The following is a description of a gene set: Genes having at least one occurrence of the motif NGRCWTGYCY in the regions spanning 4 kb centered on their transcription starting sites. This matches the TP53 transcription factor binding site V$P53_02 (v7.4 TRANSFAC). studied in species Homo sapiens Human Gene Set: P53_02, and this is the list of marker genes: SYT4, GNG3, CA9, NRG1, LIPT2-AS1, PPP1R12A, GPD2, SEMA7A, DDR1, S100PBP, KDM4C, CITED4, CRAT, MYH11, HCAR2, DTNA, DNALI1, GCNT2, MDM2, HIP1R, SRSF5 (NCBI Gene Id 6430), BCAM, HOXB1, MDK, RAB1B, TJP2, RAP1B, DSCAML1, VCPKMT (valosin containing protein lysine methyltransferase), REPIN1, ESRRG, DNAH6, MYOT, CIDEC, PTH1R, CALD1, TRIM29, LINC01565, MIP, SLC12A6, RTL3, SBF2, MEMO1, ELF4, PLA2G4E (phospholipase A2 group IVE), LZTR1, ACSL5, PSME2, HS6ST3, SLITRK1, MBNL1, SLITRK4, CTNND2, NUP93, MBNL2, MRC2, BCL11A (NCBI Gene Id 55085), SUMO4, NAPG, TMEFF1, FBRS, BRAF, ASIC4, KRT15, CXXC4, PITPNC1, HIC1, KDM2A, CPNE1, PKP3, NACC1, NIPBL, MMP28, CARMIL3, ZNF654, PTPN22, ARRDC4, SH3BP1, EPB41L1, NTRK3, SRSF6 (NCBI Gene Id 6431), H3-3A, EI24, ELK3, PRKAG1, FLRT1, MAF, SLC25A17, ARHGAP44, ASIC2, MITF, TMC7, DYRK1B, WBP1L, VAV3, HNRNPA0, COPB1, LMTK2, GABRR2, ERO1B, LPP, NXPH1, KIF16B, SYT13, MLEC, DSEL, SRRM4, PML, MARCHF1, PRDX5, FILIP1, GADD45B, RHOBTB2, PLCB3 (NCBI Gene Id 5331), SOX5, HOXA11, BCL11B, TRERF1, NDP, TFAM, CTRL, MBD6, OTX1, PRDM8, RORC, PTPA, PAK5, ENPP2, OPA3, CHUK, MAGEL2, ATP6AP1, CNR1, RPS27L, ANKRD53, MAP4, INHBB, ABCA12, RNF144B, TFDP2, FAM83H, SCN2A, SOX4, HMGN3, TSC22D1, MECR, DCAF7, PITX3, CHRM1, MTA2, LRRK1, ANXA1, STARD8, POLR1G, SLC1A3, ADAMTS4, PREX2, NUDCD1, OTX2, CACNB2, NR4A3, KBTBD8, RNF17, DENND2B, MEIS2, PPL, DNAJB5, TRMT112, PTPRG, AKAP6, AIM2, PIK3R2, PLCB1, DGKZ, MYL3, C6orf62, GATA4, DDIT3, FHDC1, MAP1LC3A, PABIR3 (NCBI Gene Id 159091), PRRX1, FOSL1, NUP54, HIPK1, BCOR, RNF31, ADGRB1, LINC00305, USP48, ZMAT3, SP8, INKA1, GPR174, RHOBTB1 (Rho related BTB domain containing 1), PPIP5K1, EIF4G2, NRXN3, ZNF362 (zinc finger protein 362), SOAT1, CD68, PIDD1, MINDY4, AHNAK, AEN, CITED1, LRIT3, RPS19, SH3GLB2, ETV1, DAB2IP, EGFR, RAB44, GAD1, DHX30, SSTR3, NDUFS2, MAP2K5, FOXG1, FUT11, ABCC5, CELF6, POMZP3, PPP2R5B (protein phosphatase 2 regulatory subunit B'beta), DMD, FGF20, NXPH4, AKT2, BMPR2, CDYL, PPM1J, CACNG2 (NCBI Gene Id 10369), GPX1, TICAM1, CRAMP1, ZHX2 (zinc fingers and homeoboxes 2), SNIP1, GCC1, CDKN1A, TRAF4, BSCL2, ARL14EP, RAI1, RARB, NRBP2, PRDM12, CCP110, CACNA1E, SPATC1, WHRN, ASCL4, TBX2, ADO, GRIN2A, MYH1 (NCBI Gene Id 4619)